Given this list of marker genes Cer1, Igsf1, Csnk2b, Mir210, Dact1, Acvr1, Fst, Dact2, Fgf9, Fstl3, Magi2, Fkbp1a, Nodal (NCBI Gene Id 21792), Acvr2b, Dmrt1, Acvr1b (activin A receptor, type 1B), Synj2bp, Lefty1, Men1, Smad6, Lemd3, Smad7, Zc3h3 (zinc finger CCCH type containing 3), Ski, Acvr2a, Dand5, Smurf1, Fgf10, here is a description of the gene set: species: Mus musculus Any process that modulates the frequency, rate or extent of the activity of any activin receptor signaling pathway. Mouse Gene Set: GOBP_REGULATION_OF_ACTIVIN_RECEPTOR_SIGNALING_PATHWAY